The following is a description of a gene set: Mouse Gene Set: GOBP_GENERAL_ADAPTATION_SYNDROME_BEHAVIORAL_PROCESS studied in species Mus musculus The set of behavioral processes that occur as part of the general adaptation syndrome, the response of the body to a strong, stressful stimulus., and this is the list of marker genes: Hcn1, Crhr1, Tmem74, Penk, Zfp212